Given this list of marker genes Pitx2, Adamts19, Dchs1, Gata5, Pde2a, Notch2, Acvr1, Gata3, Naglu, Lix1l, Rb1, Notch1, Zfpm2, Axin2, Slit2, Hey2, Tgfbr2, Heyl, Tbx20, Matr3, Robo2, Hey1, Smad6, Stra6 (stimulated by retinoic acid gene 6), Gata4, Smad2, Slit3, Ccn1, Smad4, Tie1, Fgfrl1, Rbpj, Tnfrsf1b, Tgfb2, Efna1, Bmpr2, Mtor, Rhoa, Bmp4 (bone morphogenetic protein 4), Aplnr, Bmpr1a, Dll4, Scx, Pcdha9, Mdm4, Prdm1, Olfm1, Gja5, Sox4, Mef2c, Zbtb14, Zfpm1, Adamts5, Eln, Tgfb1, Emilin1, Robo1, Jag1, Bmp2, Nos3 (nitric oxide synthase 3, endothelial cell), Twist1, Nfatc1 (NCBI Gene Id 72364), Mdm2, Adamts9, Tbx5, Shox2 (NCBI Gene Id 352985), Tnfrsf1a, Sox9, Fam114a1, Hectd1, here is a description of the gene set: studied in species Mus musculus The progression of a heart valve over time, from its formation to the mature structure. A heart valve is a structure that restricts the flow of blood to different regions of the heart and forms from an endocardial cushion. Mouse Gene Set: GOBP_HEART_VALVE_DEVELOPMENT